The following is a description of a gene set: Human Gene Set: GOBP_EPIGENETIC_PROGRAMMING_IN_THE_ZYGOTIC_PRONUCLEI species: Homo sapiens The global programming of epigenetic modifications in the zygote following fertilization. The paternal genome undergoes active DNA demethylation before the first cell division, while the adjacent maternal genome is protected from this process., and this is the list of marker genes: MORC1, SUV39H2, DCAF13, AXIN1, TLE6, KDM1B, STPG4, METTL23, DNMT3L, TET3, PADI6, DDB1, ASIP, DPPA3, SUV39H1, ZNF445